Given this list of marker genes SSUH2, PLXNC1, SRPX, WWC1, VNN1, FBN1, FMO1, NECTIN2, DCN, CPE, SCCPDH, LUM, CCL19, F2RL1, THY1, GLS, HSPA5, DHRS7, ANK3, PPIC, ACSL4, MUC13, here is a description of the gene set: Genes up-regulated in the extracellular matrix-type subclass of hepatocellular carcinomas. Sets created as part of a metaanalysis of nine public transcriptomic datasets merged into a metadataset including 1133 human hepatocellular carcinomas obtained after curative resection. For platform descriptions of each one of the 9 datasets, see Figure 1B in Désert et al., Hepatology (2017), 66: 1502-1518. studied in species Homo sapiens Human Gene Set: DESERT_EXTRACELLULAR_MATRIX_HEPATOCELLULAR_CARCINOMA_SUBCLASS_UP Hepatocellular carcinomas (HCCs) exhibit a diversity of molecular phenotypes, raising major challenges in clinical management. HCCs detected by surveillance programs at an early stage are candidates for potentially curative therapies (local ablation, resection or transplantation). In the long term, transplantation provides the lowest recurrence rates. Treatment allocation is based on tumor number, size, vascular invasion, performance status, functional liver reserve and on the prediction of early (< 2 years) recurrence, which reflects the intrinsic aggressiveness of the tumor. Well-differentiated, potentially low-aggressiveness tumors form the heterogeneous molecular class of non-proliferative HCCs, characterized by an approximate 50% beta-catenin (CTNNB1) mutation rate. To define the clinical, pathological, molecular features and the outcome of non-proliferative HCCs, we constructed an 1133-HCC transcriptomic metadata set and validated findings in a publically available 210-HCC RNAseq set. We show that non-proliferative HCCs preserve the zonation program that distributes metabolic functions along the porto-central axis in normal liver. More precisely, we identified two well-differentiated, non-proliferation subclasses, namely Periportal-type (wild-type CTNNB1) and Perivenous-type (mutant CTNNB1), which expressed negatively correlated gene networks. The new Periportal-type subclass represented 29% of all HCCs; expressed an HNF4A-driven gene network, which was down-regulated in mouse Hnf4a-KO mice; were early-stage tumors by BCLC, CLIP and TNM staging systems; had no macrovascular invasion and showed the lowest metastasis-specific gene expression levels and TP53 mutation rates. Also, we identified an 8-gene Periportal-type HCC signature, which was independently associated with the highest 2-year recurrence-free survival by multivariate analyses in two independent cohorts of 247 and 210 patients. Conclusion: Well-differentiated HCCs display mutually exclusive periportal or perivenous zonation programs. Among all HCCs, Periportal-type tumors have the lowest intrinsic potential for early recurrence after curative resection. from publication Désert R, Rohart F, Canal F, Sicard M, Desille M, Renaud S, Turlin B, Bellaud P, Perret C, Clément B, Lê Cao KA, Musso O (PMID 28498607)